Given this list of marker genes CDV3, MEIS2, TMEM267, UNC80, TRPC5, MZT1, SOCS4, TSEN15 (tRNA splicing endonuclease subunit 15), FAM120A (NCBI Gene Id 23196), CBX3, PTBP3, SGIP1, SMG7 (SMG7 nonsense mediated mRNA decay factor), FZD1, PROK2, R3HCC1L, WWC2, SATB1 (SATB homeobox 1), FABP7, CREBRF, ITCH, SLC24A2, HAUS2, MATR3, ARHGAP21, MIGA1, FER, NAIP (NCBI Gene Id 82693), FAM78B, CCDC34, UNC5D, HEXIM1, FAM20A, NUFIP2, CNOT9, SERPINB7 (serpin family B member 7), ZDHHC17, LDAF1, ST8SIA4, LANCL2, GLRA4, STXBP5, STAM2, PRMT2, SIDT1, CLEC3A, KCND2, PHF12, ATL3, SLITRK4, PI4K2A, ZNF24, TMEM167A, KCNJ16, PXK, EIF4A2, ADGRF1, PGRMC1, DDX6, MAP9, MOB1B, TMEM196, DIPK2A, KPNA4, PHF14, LFNG (LFNG O-fucosylpeptide 3-beta-N-acetylglucosaminyltransferase), PARVA, UBXN2B, CRIPT, CAPS2 (calcyphosine 2), TAS2R20 (taste 2 receptor member 20), TRIQK, POLR3F, CNOT7, SH3GLB1, ZNF716, DBT, ROBO1, BAG5, RNF168, POTEE, NYAP2, GALNT7, AAK1, SVIL, CACNA2D3, GTF2A1, TRHDE, SLC32A1, PARP15, GK5, FGD6, NRG2, RGS18, MAPK8, ZFP28, SV2C, NEUROD1, GDPD1, TRIM33, ZNF765, POU2F1, CEP57L1, ATL2 (atlastin GTPase 2), ATP13A3, N6AMT1, ERICH1, WDR77, ZFP36L1, STAG2, PTPRD, FAM199X, NR3C1, SFXN5, RBM25, UBXN4 (NCBI Gene Id 23190), U2SURP, FREM2, HSD17B11, MAP3K20, GFPT1, ARID2, MINAR1, B3GLCT, SYT10, ZNF34, GOLIM4, NABP1, ITGA6, POTEJ, PIGR, NPAS3, LRCH2, COL3A1, ZNF546, GNPDA1, INSR, STRN, SYAP1, ZNF302, IKZF3, KIF1B, PPP4R3B, MOB3B, TNFAIP8 (NCBI Gene Id 25816), SCAI, AGPS, CMTM6, SRBD1, FUT9, SLC35C1, BROX, MED13L, SPOPL, IHO1, BAG3, RPS6KA3, KCNK1, CAPZA2, DCAF4L2, GORAB, AGO1, SDR42E1, VPS26C, CA12, ASAH1, UNC13C, SHROOM3, MBD5, TSPAN12, PDE8B, IKZF2, TIMM8A, FABP2, DNAJC25, ZFP1, SHC4, CLOCK, SLC25A15, DDI2, CAVIN2, MTOR, ASB7, SNTB2, UHRF2, ZFX, TMEM215, RB1CC1, KLHDC8A, MEGF11, PRKAA2, BHLHE22, RC3H1, OLFM3, ZBTB20, LHFPL3 (LHFPL tetraspan subfamily member 3), L1CAM, EHF, SLC16A7, ZNF705EP, EIF5A2, C9orf72, JMJD1C, KNG1 (NCBI Gene Id 589), DENND1B, SELENOT, KCNN3, ENSG00000215022, RBM20, KCNMB4, MYOCD, TRDN, SMG1, AHCTF1, ERBIN, ZNF675, B3GAT1, FBXL5, PRUNE2, SHE (NCBI Gene Id 126669), NHSL1, PCDH11Y, CXCL9, LPGAT1, ABCD4, CPEB4, MTF1, TMEM47, GLS, PRPF38A, SYNJ1, FAM216B, SLC19A4P (solute carrier family 19 member 4, pseudogene), IFT20, UNC5CL, PTK2, ZNF208 (zinc finger protein 208), SMARCC1, EPHA5, PABPC4L, RAB3C, USP12, ZNF480, RGS13, PCSK1, ZDHHC2, TNFRSF21, TCF12, TBCA, CCR6, STAT1, GABPB1, NFAT5, MRPL42, TAF1, CLEC1A, DUSP10, MAGED1, SLC30A6, RBFOX2, CPSF6, ANKRD49, MASTL, IFT43, TBX18, PHF20L1, MARCHF6, RTKN2, IPO8, DIS3L2, PABIR2, DIO1, SAMTOR, ARPC5, RBM41, TRMT1L, TMEM135, BDNF, ZBTB41, here is a description of the gene set: Genes predicted to be targets of miRBase v22 microRNA hsa-miR-4762-3p in miRDB v6.0 with MirTarget v4 prediction scores > 80 (high confidence targets). species: Homo sapiens from publication Chen Y, Wang X (PMID 31504780) Human Gene Set: MIR4762_3P